Given this list of marker genes DLG4, ABCB9, HSD17B11, UGT2B17, ACOT8, CEL, GSTK1, HMGCL, ITGB1BP1, CTPS1, SLC25A17, GNPAT, SLC25A4, ELOVL5, IDH2 (isocitrate dehydrogenase (NADP(+)) 2), CLN6, SCGB1A1, SIAH1, ACOX1, RETSAT, NUDT19, ABCC5 (ATP binding cassette subfamily C member 5), SLC35B2, CDK7, ALDH1A1, ABCB4, HSD17B4, MSH2, ISOC1, TSPO, SMARCC1, ABCD2, ESR2 (estrogen receptor 2), CLN8, SCP2, YWHAH, PEX14, TOP2A, CACNA1B, DIO1, PEX11A, HRAS, PEX11B, CRABP1, SLC25A19, ALDH9A1, HSD11B2, IDH1, ACAA1, PRDX5 (peroxiredoxin 5), MVP, PEX2, ABCC8, ABCB1, ATXN1, HAO2, PEX13, FIS1, VPS4B (NCBI Gene Id 9525), CADM1, STS, HSD3B7, SOD1, SEMA3C, BCL10, SLC27A2, CRAT, FADS1, ERCC1, NR1I2, DHCR24, ERCC3, SERPINA6, ACSL1, MLYCD, RXRG, SLC23A2, FABP6, SOD2 (NCBI Gene Id 79099), ABCD1, EPHX2, ECH1, IDE, EHHADH, PRDX1, ECI2, PABPC1, FDPS, CTBP1, DHRS3, CAT, CNBP, ALB, ABCD3, RDH11, IDI1, TTR, CRABP2, SULT2B1, ACSL5, ACSL4, PEX5, PEX6, LONP2, here is a description of the gene set: Human Gene Set: HALLMARK_PEROXISOME Genes encoding components of peroxisome. studied in species Homo sapiens from publication Liberzon A, Birger C, Thorvaldsdóttir H, Ghandi M, Mesirov JP, Tamayo P (PMID 26771021)